Given this list of marker genes Ddb2, Xpa, Terf2, Ercc8, Xpc, E2f1, Polh, Ptch1, Ercc2, Gadd45a, here is a description of the gene set: Mouse Gene Set: MP_INCREASED_INCIDENCE_OF_TUMORS_BY_UV_INDUCTION from publication Motenko H, Neuhauser SB, O'Keefe M, Richardson JE (PMID 26092688) studied in species Mus musculus Mouse genes annotated to increased incidence of tumors by UV-induction (MP:0004501) retrieved from the Mouse Genome Informatics database via MouseMine